Given this list of marker genes NCF1, IL12RB1, CYBB, CYBA (cytochrome b-245 alpha chain), NCF2, MBL2, here is a description of the gene set: species: Homo sapiens Increased susceptibility to Klebsiella infections, as manifested by recurrent episodes of Klebsiella infection. Recurrent Klebsiella infections Human Gene Set: HP_RECURRENT_KLEBSIELLA_INFECTIONS